The following is a description of a gene set: studied in species Homo sapiens Unwinding a DNA helix in the 5' to 3' direction, driven by ATP hydrolysis. Human Gene Set: GOMF_5_3_DNA_HELICASE_ACTIVITY, and this is the list of marker genes: HELB (DNA helicase B), DNA2, ERCC2, ZGRF1, TWNK, DDX11, BRIP1, PIF1, IGHMBP2